Given this list of marker genes RAG1, DOCK11, PAX1, SLC39A14, RAG2, NBN, MALT1, TPP2, here is a description of the gene set: Mastoiditis Human Gene Set: HP_MASTOIDITIS species: Homo sapiens